Given this list of marker genes Ffar1, Grp, Gnb3, Gcg, Gpr119, Gnb1, Dpp4, Gip, Gnat3 (G protein subunit alpha transducin 3), Ffar4, Lep, Gng13, here is a description of the gene set: species: Mus musculus Incretin synthesis, secretion, and inactivation Mouse Gene Set: REACTOME_INCRETIN_SYNTHESIS_SECRETION_AND_INACTIVATION